The following is a description of a gene set: Human Gene Set: GOBP_REGULATION_OF_LAMELLIPODIUM_ASSEMBLY Any process that modulates the rate, frequency or extent of the formation of a lamellipodium, a thin sheetlike extension of the surface of a migrating cell. studied in species Homo sapiens, and this is the list of marker genes: MSTN, CARMIL2 (NCBI Gene Id 146206), MTOR, FRMD7, RAC2, AVIL, FER, DMTN, PIK3R1, FSCN1, AUTS2, SLIT2, PLXNB3, WAS, PIK3CA, WASF2 (NCBI Gene Id 10163), TWF2, EPHA2, NCKAP1 (NCBI Gene Id 9864), ACTR3, ARPC2, PLCE1, ACTR2, AKIRIN1, TWF1, CDC42, RAC1, MIR196A1, HSP90AA1, CYFIP1, MIR214, WNT1, HRG (histidine rich glycoprotein), ABI2, ABI3, CFL1, BIN3, BRK1, CLRN1, OCLN